Given this list of marker genes Dlat, Dld, Pdha1, Pdha2, Pdhx, Pdhb, here is a description of the gene set: studied in species Mus musculus Mouse Gene Set: REACTOME_PDH_COMPLEX_SYNTHESIZES_ACETYL_COA_FROM_PYR PDH complex synthesizes acetyl-CoA from PYR